Given this list of marker genes Tln2 (NCBI Gene Id 70549), Dctd, Senp7, Tmpo, Aak1, Isl1, Zfp14, Psma8 (proteasome subunit alpha 8), Pate3, Vmac, Pcdh10, Cep170, Prrx1, Lrriq3 (leucine-rich repeats and IQ motif containing 3), Bmp8b, Gnai1, Naa11, Gpr12, Septin5, Ccl9, Cd79a, Fyttd1, Fam118a, Raver2, Cdt1, Ubp1, Igsf11, Stradb, Pccb, Arih1 (ariadne RBR E3 ubiquitin protein ligase 1), Tlk2, Chl1, Gper1, Cyp2b19, Sspn, Syt16, Fgf15, Larp1, Ldb2, Armc3, Casp2, Mal (myelin and lymphocyte protein, T cell differentiation protein), Pou4f1, Trub1, here is a description of the gene set: Mouse Gene Set: MIR_3471 from publication Chen Y, Wang X (PMID 31504780) Genes predicted to be targets of miRBase v22 microRNA mmu_miR_3471 in miRDB v6.0 with MirTarget v4 prediction scores > 80 (high confidence targets). studied in species Mus musculus